The following is a description of a gene set: Cristae are invaginations of the inner mitochondrial membrane that extend into the matrix and are lined with cytochrome complexes and F1Fo ATP synthase complexes. Cristae increase the surface area of the inner membranes allowing greater numbers of respiratory complexes. Cristae are also believed to serve as "proton pockets" to generate localized regions of higher membrane potential. The steps in the biogenesis of cristae are not yet completely elucidated but the formation of the Mitochondrial Contact Site and Cristae Organizing System (MICOS, formerly also known as MINOS, reviewed in Rampelt et al. 2016, Kozjak-Pavlovic 2016, van der Laan et al. 2016) and localized concentrations of cardiolipin are known to define the inward curvature of the inner membrane at the bases of cristae. MICOS also links these regions of the inner membrane with complexes (the SAM complex and, in fungi, the TOM complex) embedded in the outer membrane. CHCHD3 (MIC19) and IMMT (MIC60) subunits of MICOS also interact with OPA1 at the inner membrane.<br>Formation of dimers or oligomers of the F1Fo ATP synthase complex causes extreme curvature of the inner membrane at the apices of cristae. Defects in either MICOS or F1Fo ATP synthase oligomerization produce abnormal mitochondrial morphologies. part of: Mitochondrial biogenesis Reactome Pathway: Cristae formation studied in species Homo sapiens, and this is the list of marker genes: HSPA9, MTX2, ATP5MF, DMAC2L, MT-ATP6, ATP5PF, APOO, DNAJC11, ATP5PD, APOOL, ATP5F1E, ATP5MC2, CHCHD6, MICOS13, ATP5F1C, SAMM50, MICOS10, ATP5F1A, CHCHD3, ATP5PB, MTX1, IMMT, ATP5F1B, ATP5ME, ATP5F1D, ATP5MJ, ATP5PO, MT-ATP8 (NCBI Gene Id 4509), TMEM11, ATP5MC1, ATP5MG (ATP synthase membrane subunit g), ATP5MK, ATP5MC3